Given this list of marker genes HNF1B, MT-TK, MT-TV, NPHP3, MT-ND6, MYOCD, MT-ND4, MT-ND5, MT-TL1, MT-ND2, MT-ND1, MT-ATP6, MT-TW, MT-ND3, here is a description of the gene set: Multiple glomerular cysts Human Gene Set: HP_MULTIPLE_GLOMERULAR_CYSTS studied in species Homo sapiens The presence of many cysts in the glomerulus of the kidney related to dilatation of the Bowman's capsule.